The following is a description of a gene set: studied in species Mus musculus Mouse Gene Set: chr16A2, and this is the list of marker genes: Spidr, Ube2v2, Mzt2, Cebpd, Dnm1l, Yars2 (tyrosyl-tRNA synthetase 2 (mitochondrial)), Prkdc, Pkp2, Gm20082, Gm5481, Mcm4, Gm7085, Gm7765, Gm18334, Gm7748